Given this list of marker genes BBS4, IFT74, CEP19, SDCCAG8, IFT172, SIN3A, BBS5, CFAP418, IFT27, FRA10AC1, TRIM32, BBS9, BBS2, CEP290 (centrosomal protein 290), APTX, MKKS, WDPCP, TTC8, ARL6, BBS10, NRCAM, BBS1, SCLT1, MLXIPL, ELN, BBS12, BBIP1, SCAPER (S-phase cyclin A associated protein in the ER), ABL1, BBS7, UBAP2L, GNB2, LZTFL1, MKS1, NPHP1, PRKD1, here is a description of the gene set: studied in species Homo sapiens An abnormal distribution of eyebrow hair growth in the medial direction. Medial flaring of the eyebrow Human Gene Set: HP_MEDIAL_FLARING_OF_THE_EYEBROW